The following is a description of a gene set: studied in species Homo sapiens Human Gene Set: REACTOME_PRESYNAPTIC_DEPOLARIZATION_AND_CALCIUM_CHANNEL_OPENING Presynaptic depolarization and calcium channel opening, and this is the list of marker genes: CACNB4, CACNB3, CACNA1A, CACNB2, CACNA1E, CACNA2D2, CACNA1B, CACNB1, CACNG2, CACNG4, CACNA2D3